The following is a description of a gene set: species: Homo sapiens Well-demarcated area(s) of partial or complete depigmentation in the macula, reflecting atrophy of the retinal pigment epithelium with associated retinal photoreceptor loss. Macular atrophy Human Gene Set: HP_MACULAR_ATROPHY, and this is the list of marker genes: MERTK, ELOVL4, ATF6, MAPKAPK3, GBA1, CFAP418, PRPH2, RLBP1, TNFRSF11B, RPGRIP1, ARL2BP, PRPF31, HK1, CNNM4, PCYT1A, C1QTNF5, DRAM2, HLA-A, GUCY2D, EFEMP1, LZTFL1 (NCBI Gene Id 54585), CFI, RP9 (NCBI Gene Id 6100), SLC24A1, CFH, NMNAT1, CDH3, BBS5, GUCA1A (guanylate cyclase activator 1A), KCNV2, SH3BP2, YARS1, UNC119, DHX38, PLK4, SAMD7, RHO, EPG5, RDH5, SIX6, AIPL1, WDR19, IFT140, SLC6A6, RAX2, NRL, RS1